Given this list of marker genes GJB3, PSMB8, PITPNC1, SMYD5, CRYBG1, PITPNM1, ACTG1, TP53INP2, CYP21A1P, NCAM2, SNAI2, TMEM41B, RECK, PPIH, CR1L, RAI1, DOLPP1, NFE2, SPSB2, TNFRSF1B, ZFP36, GPR27 (NCBI Gene Id 54330), HSPH1, SEPTIN7, NR0B1, DDX46, TBL3, FBL, AGAP2, CUBN, RPP14, FOSB, PVALB, H2BC5, PIGR, ST3GAL2, SEMA4A, FLT3, KLHDC2, BAG2, SAT1, SHMT1, CD180, COPG1, C1orf174, HOXA11 (NCBI Gene Id 3207), FGFR4, HSD17B8, TSPAN33, ARFGAP2 (ADP ribosylation factor GTPase activating protein 2), GSTM5, PON3, SEMA3A, DHH, SET, PRKCA, NMT2, ENO3, IL10RA, WDR75, CMIP, HRH2, POLE2, CCN5, SORBS3, SCEL, GRIN1, CRISP3, SRC, BASP1, HSD17B7, HLA-DMA, CTSK, XCR1, MMP14, DHPS, BCL2, ELOVL5, RPN1, SH2B3, INPP4A, PNP, NOS3, POLR1E, IL3RA, SPRY4, PDX1, HTR5A, SMARCD1, CEL, ADGRL1 (adhesion G protein-coupled receptor L1), G6PC3, CTNNBIP1, SLC6A9, LUC7L2, MPDZ, LDB2, GPN1, GADD45G, AATK, MYLK, FGFR3, EXOSC5, RUVBL1, RCE1, NPR3, SLC35G6, TENT5A, RGS2, ZNF532, LARP7, TM2D1, BNIP1, NR4A2, PSMB10, FOXK1, FMC1, EGR2, B4GALT3, RPA2, ZP2, HSD17B2, PRNP, ADPRH, EIF4G3, FLNB, EXT1, CHGB, FER, FOXM1, DES, CNN2, IKZF4, NSMF, ALAS2, RETREG1, OC90, HTRA2, FURIN, FOXA3, TAP1, PLPPR2, GAS6, AP1S1, IFRD2, ELF5, NOLC1, ARID1A, MAEA, GAR1, TFF1, MED14, FMNL3, SLC2A8, RPS6KA1, LCP1, GBP2, POLR1A, BMI1, HELLS, DNPH1, NPPC, CS, ARPC2, AOPEP (aminopeptidase O (putative)), CSF3R, DYNC1H1, EIPR1, CLCA1, MCUR1, EIF4E, MRPL55, DIPK2A, TYR, STAU1, TIMELESS, SLC25A6 (solute carrier family 25 member 6), MAPRE2, EYA4, ABHD14A (NCBI Gene Id 25864), RFC2, RHOB, RAMP3, SPRED2, KLF1, FMR1NB, GZMB, RGS10, TLE4, CD53, AAK1 (NCBI Gene Id 652453), PLXNA3, SERPINB4, HIP1R, HSP90B1, PER1, HTT, KRT25 (NCBI Gene Id 147183), APOM, HSPA4, here is a description of the gene set: Comparison of gene expression changes in CD4+CD8+ thymocytes following engagement of TCR with anti-Valpha or Vbeta antibodies Human Gene Set: GSE1448_ANTI_VALPHA2_VS_VBETA5_DP_THYMOCYTE_DN studied in species Homo sapiens Genes down-regulated in comparison of CD4 CD8 thymocytes stimulated with anti-Valpha2 antibodies versus CD4 CD8 thymocytes stimulated with anti-beta5 antibodies. from publication Niederberger N, Buehler LK, Ampudia J, Gascoigne NR (PMID 15661827)